The following is a description of a gene set: Delayed pubic bone ossification Delayed maturation and calcification of the pubic bone. Human Gene Set: HP_DELAYED_PUBIC_BONE_OSSIFICATION studied in species Homo sapiens, and this is the list of marker genes: COL2A1, GJB6 (gap junction protein beta 6), SIK3, CBFB, GJB2, RUNX2, NKX3-2